The following is a description of a gene set: studied in species Homo sapiens The chemical reactions and pathways involving snoRNA, small nucleolar RNA, any of a class of small RNAs that are associated with the eukaryotic nucleus as components of small nucleolar ribonucleoproteins. They participate in the processing or modifications of many RNAs, mostly ribosomal RNAs (rRNAs) though snoRNAs are also known to target other classes of RNA, including spliceosomal RNAs, tRNAs, and mRNAs via a stretch of sequence that is complementary to a sequence in the targeted RNA. Human Gene Set: GOBP_SNO_S_RNA_METABOLIC_PROCESS, and this is the list of marker genes: RNF113B, EXOSC6, EXOSC4, RNF113A, FBLL1, EXOSC10, EXOSC5, NUDT16, FBL, TENT4B, ZCCHC7, PARN (NCBI Gene Id 5073), LARP7, EXOSC3, EXOSC2, DKC1, NUDT16L1